Given this list of marker genes Anxa5, Uqcrfs1, Epb41l2, Tmed4, Zfp36, Ap2s1, Mir24-2, Sf3b4 (splicing factor 3b, subunit 4), Rsrp1, Ccdc80, Itm2a, Sdf4, Cst3, Bri3, Gpr132, Anxa2, Psap, Irgm1, Maged1, Laptm4b, Drap1, Ranbp1, Rbm38, Man2b1, Slc43a3 (NCBI Gene Id 58207), Crlf2, Shisa5, B2m (NCBI Gene Id 12010), Inmt, Psip1, Dtx1, Gnmt, Ankrd13a, Dohh, Anxa4, Ppt1, Actr10, Id3, Rpl13a, Gadd45gip1, Tmed3, Saraf, Itgb1, Mycbp2, Rogdi, Hnrnpm, Map3k1, Ubl7, P2ry13, Rbm39, Lgals3bp, Dusp5, App, Rab11a (NCBI Gene Id 53869), Arhgdia, Cd81, Rbl2, Tex261, Limd2, C1qb, Vars1, Tgfbi, Sp140l2, Jun (NCBI Gene Id 16476), Emd, Ogdh, Capn2 (calpain 2), Capg, P2ry10, Apbb1ip, Igfbp5, Ccdc88c, Mgll, Nxpe3, Lgals3, Plpp3, Dnajc3, Itm2b, Tle5, Arpc4, 4930523C07Rik (RIKEN cDNA 4930523C07 gene), Fcgrt, Pou2f2, Scand1, Supt5, Vcam1, Klf13, Zfand5, Cd38, Fam204a, Siglech, Ctsd, Snrpc, Ifi30, Senp6, Atp5f1d (ATP synthase F1 subunit delta), Rps3, Anp32b, Trim35, Irf8, Rhob, Ppm1h, Tie1, Cox5a, Sipa1, Ptma, Sidt2, Ctsl, Agpat1, Car2, Mxra8, Hsp90b1, Gpx4, Lrp10, Ctsh, Ifngr1, Fam43a, Clic4, Kdm6b, Adrm1, Itm2c, Isyna1, Oaz1, Prnp, Dhrs3, Cd9 (CD9 antigen), Serpinb6a, Csnk1d, Tmbim1, Syt11, Cd36, Tmt1a, Rab43, Tomm6, Yy1, Psmb8, Jund, Cdkn1a, Dcn, Gnb1, Fam13b, Fabp4, Prdx5, Csrnp1, Dcun1d1, Cebpd, Pfn1, Emc10, Grk6, Ddrgk1, Kpna4, Tmem160, Aldh2, Rnaset2b, Serpine2, H1f2, Tubb4a, Rabac1 (NCBI Gene Id 80486), Gas7, Ubr4, Abhd12, Ncs1, Vim (vimentin), Sp140l1, Bsg, Acta2, Slc48a1, Cd151, Cd68, Tspan2, Pold4, Tmem109, Csnk2a1, Cfl1, Tmem176a, Prr13, Gstm1, Atp5f1c, Prelid1, Pcmt1, Crip2, Wbp1l, Tob2, Icam1, Map1lc3a, Timp2 (NCBI Gene Id 52894, tissue inhibitor of metalloproteinase 2), Ddx50, Fkbp8, H2-K1, Pura, Pltp, Aqr, Arpc1b, Egr1, Khnyn, Tmem176b, Ralbp1 (NCBI Gene Id 268968), Klf2, Rcn3, Psmb9 (proteasome (prosome, macropain) subunit, beta type 9 (large multifunctional peptidase 2)), Ppp1r35, Serping1, Apoe, Fcer1g, Rasgrp2, Tagln2, Get1, Pi16, Mfge8, Trir, Thbd, Grb2, Grn, Mbp, Rnase6, Slc12a9, Pum2, Errfi1, Ehd2, Efcab14, Ino80e, Pkm, Lair1, Xbp1, Vsir (V-set immunoregulatory receptor), Snrpa (small nuclear ribonucleoprotein polypeptide A), Atp2c1, Nub1, Mfap5, Pmaip1, Tmem59, Eif3c, Tpi1, Myo6, Tram1, Cav1, Ptprcap, 5031425E22Rik, Lmna, Bst2, Atp1a1, Akr1a1, Nfkbib, Ctsz, Tmsb10, Tppp3, Tubb6, Tgfbr1, Cirbp, Neat1, Car3 (carbonic anhydrase 3), Gadd45g, Exosc6, Arf4, H2ax, Tpm1, Rnf10, Smim14, Reep5, Tln1, Wdr1, Cnn3, Ube2j2, Os9, Sgk1, Selenop, Stk24, Plod1, Laptm4a, Hexb, Ly6a, Ctsb, Selplg, Mt2, Abi3, Plekho1, Eci2, Fahd1, Sf3b2, H1f0, Ubxn1 (UBX domain protein 1), Rad9a, Gsn, Cd79a, Lyz2, Scamp2, Pttg1ip, Cyba, Pkig, Clptm1 (cleft lip and palate associated transmembrane protein 1), Selenow, Cotl1 (coactosin like F-actin binding protein 1), here is a description of the gene set: from publication Tabula Muris Consortium (PMID 32669714) species: Mus musculus Mouse Gene Set: TABULA_MURIS_SENIS_BROWN_ADIPOSE_TISSUE_B_CELL_AGEING